Given this list of marker genes Tmem161b, Cacnb3, Hcn4, Ank2, Slc9a1, Trpc4 (transient receptor potential cation channel, subfamily C, member 4), Kcnb1, Cnr2, Trpa1, Atp2a2, Ifng, Dlg1, Ryr2, Scn9a, Rangrf, Hcn1, Dsg2, Cacna2d1, Hnrnpa1, Camk2d, Nps, Cav1 (NCBI Gene Id 12389), Calm1, Kcnj2, Cd36, Rnf207, Slc4a3 (solute carrier family 4 (anion exchanger), member 3), Sumo1, Cnr1, Gja5, Adra1a, Gpr35, Kcnq3, Tnf (tumor necrosis factor), Tacr1, Jup, Kcnc2, Bin1, Slc8a2 (solute carrier family 8 (sodium/calcium exchanger), member 2), Fmr1, Chrnb2, Chrna5, Rapgef4, Kcnk9, Tbx18, Fgf12, Kcnq2, Flna, Fgf13, Mecp2, Calm3, Ctnna3, Calm2, Dsp, Scn5a, Ank3 (NCBI Gene Id 73013), Gba1, Cntnap2, Kcnip1, Pawr, Kcnc4, Pkp2, Cacna1c, Kcnk3, Akap9, Trpm4, Ffar3, Mtnr1b, Kcne3, Tac1, Foxp1, Cav3, Cxadr, Dsc2, here is a description of the gene set: Mouse Gene Set: GOBP_REGULATION_OF_ACTION_POTENTIAL species: Mus musculus Any process that modulates the frequency, rate or extent of action potential creation, propagation or termination. This typically occurs via modulation of the activity or expression of voltage-gated ion channels.